Given this list of marker genes PLAU, APOE, MPO, APP, PSEN1, CACNA1G, NOS3, ABCA7, PSEN2, here is a description of the gene set: Alzheimer disease species: Homo sapiens A degenerative disease of the brain characterized by the insidious onset of dementia. Impairment of memory, judgment, attention span, and problem solving skills are followed by severe apraxia and a global loss of cognitive abilities. The condition primarily occurs after age 60, and is marked pathologically by severe cortical atrophy and the triad of senile plaques, neurofibrillary tangles, and neuropil threads. Human Gene Set: HP_ALZHEIMER_DISEASE